The following is a description of a gene set: CD3-positive T cells were negatively isolated from 10 SLE patients and 9 healthy controls without SLE. All of the SLE samples and control samples were compared with one another to identify baseline differences in expression due to the disease. Next, T cell preparations from 4 of the control subjects were stimulated with either Nitric Oxide (NOC-18) 600 uM for 24hr or stimulated through CD3/CD28 for 24hr to determine which genes were responsive to these signaling mechanisms. Here, we show that activity of the mammalian target of rapamycin (mTOR), which is a sensor of the mitochondrial transmembrane potential, is increased in SLE T cells. Activation of mTOR was inducible by NO, a key trigger of MHP which in turn enhanced the expression of HRES-1/Rab4, a small GTPase that regulates recycling of surface receptors through early endosomes. Expression of HRES-1/Rab4 was increased in SLE T cells and, in accordance with its dominant impact on the endocytic recycling of CD4, it was inversely correlated with diminished CD4 expression. HRES-1/Rab4 over-expression was also inversely correlated with diminished TCRζ protein levels. Combined with follow up studies, these results suggest that activation of mTOR causes the loss of TCRζ in lupus T cells through HRES-1/Rab4-dependent lysosomal degradation. Genes down-regulated in resting CD4 T cells: healthy versus systemic lupus erythrematosus (SLE). Human Gene Set: GSE13887_HEALTHY_VS_LUPUS_RESTING_CD4_TCELL_DN from publication Fernandez DR, Telarico T, Bonilla E, Li Q, Banerjee S, Middleton FA, Phillips PE, Crow MK, Oess S, Muller-Esterl W, Perl A (PMID 19201859) studied in species Homo sapiens, and this is the list of marker genes: CEP192, CCNG1, CLMN, TMA7, NAA25, USP1, GNL2, CCDC150, FLRT2, RIBC1, RCVRN, MARVELD2, GOLIM4, DCN, PPP1R15B, NRGN, HYLS1, NOL11, PLS3, CEP170, MT-ND3, MTFR1, DSTN, OMD, PPP2CA, MIR96, DHX29, PDIK1L, NAT1, CCZ1, CENPF, NEK1, RNF11, VPS45, ERP44, HOOK1, PCDHB2, ITGAL, BAG1, DENND6B, GPT, NUDT21, CTSH, IL1A, CENPC, ABCE1, LMX1A, PCGF6, PLEKHA3, AHCYL1 (NCBI Gene Id 29039), BIVM, CLPX, SRY, FXYD7, CFAP58, GDI2, MAN1B1, BAALC, TCAF1, GABPB1, SNX1, PTMA, RALBP1, GRXCR1, CLCA1, SERBP1, PRSS41, FGGY, WDR72, AGA, BCAP29, SRGAP2, EID3, SPAM1, MIR27A, PGBD1, TRIM55, BTRC, SEMA3E, HNRNPD, MSL3, IRX5, NUSAP1, TIAL1, CNTNAP4, NR4A1, PITPNM2, GGH, ARHGAP32, RPL29, RFX5, SLAMF6, CBFB, VSIG10L, SLC46A1, PPP1R14D, PLCD1, DARS1, ATXN7L3, FGD6, ARHGAP5 (Rho GTPase activating protein 5), RAB8B, NCKIPSD, DOC2B, GABRA2, TOX2, ENO4, MIR217, PKD2L1, CALD1, CIBAR1, ANKS1A, SLC7A4, ODF2L, RUFY4, CYSLTR2, UBE2N, MATN4, MIR451A, MMD, NRBP2, KPNA3, PPM1E, HAUS6, MFSD6, SNAI3